Given this list of marker genes Alcam, Plscr1, Car2, Rrm2, Aebp1, Tgfa, Ddr1, Junb, Rbp1, Ccnd1, Ly6d, Eps15, Tceal9, Tlr6, Cd63, Col4a1, Btg3, Lpl, Spp1, Rab3d, Ltb (lymphotoxin B), Fos, Btg2, Serpine1, Tgif1, Krt8, Ccnb1, S100a11 (S100 calcium binding protein A11), Vil1, Mki67, Pdgfa, Elf3, Rhoc, D17H6S56E-5, Atf3, Cpe, H19, Serpinb6a, Tff3, Scd2, Acot10, Id1, Blnk (NCBI Gene Id 17060), Cidea, Krt18, Cdk1, Amy2a5, Igfbp1, Ets2, Twf2, Slc7a7, Cldn7, Bex1, Rbm3, Ect2 (ect2 oncogene, NCBI Gene Id 99670), Anxa2, here is a description of the gene set: studied in species Mus musculus Mouse Gene Set: BORLAK_LIVER_CANCER_EGF_UP Genes up-regulated in hepatocellular carcinoma (HCC) developed by transgenic mice overexpressing a secretable form of EGF in liver. from publication Borlak J, Meier T, Halter R, Spanel R, Spanel-Borowski K (PMID 15674348) Epidermal growth factor is an important mitogen for hepatocytes. Its overexpression promotes hepatocellular carcinogenesis. To identify the network of genes regulated through EGF, we investigated the liver transcriptome during various stages of hepatocarcinogenesis in EGF2B transgenic mice. Targeted overexpression of IgEGF induced distinct hepatocellular lesions and eventually solid tumours at the age of 6-8 months, as evidenced by histopathology. We used the murine MG U74Av2 oligonucleotide microarrays to identify transcript signatures in 12 tumours of small (n=5, pooled), medium (n=4) and large sizes (n=3), and compared the findings with three nontumorous transgenic livers and four control livers. Global gene expression analysis at successive stages of carcinogenesis revealed hallmarks linked to tumour size. A comparison of gene expression profiles of nontumorous transgenic liver versus control liver provided insight into the initial events predisposing liver cells to malignant transformation, and we found overexpression of c-fos, eps-15, TGIF, IGFBP1, Alcam, ets-2 and repression of Gas-1 as distinct events. Further, when gene expression profiles of small manifested tumours were compared with nontumorous transgenic liver, additional changes were obvious and included overexpression of junB, Id-1, minopontin, villin, claudin-7, RR M2, p34cdc2, cyclinD1 and cyclinB1 among others. These genes are therefore strongly associated with tumour formation. Our study provided new information on the tumour stage-dependent network of EGF-regulated genes, and we identified candidate genes linked to tumorigenes and progression of disease.